The following is a description of a gene set: Human Gene Set: HP_ASCITES studied in species Homo sapiens Accumulation of fluid in the peritoneal cavity (between the layers of the peritoneum that lines the abdomen). Ascites, and this is the list of marker genes: TRIM37, FARSB, ASXL1 (NCBI Gene Id 23393), ARHGAP31, DCDC2, IRF5, GNB2, FH, DIS3L2, SEMA4D, NPC2, GNA11, MTO1, WDR35, SCN4A, ATP6AP2, CCBE1, GBE1, TMEM67, DGUOK, DEF6, TAPT1, PRKCSH, SPP1, TSC1, GRIP1, TNPO3, FSHR, KRT18, TNFSF15, TRIP13, BUB1B, CD55, UBR1, IL12A, TSC2, MRPS22, CBL, POU2AF1, LTBP4, DNASE1L3, ENPP1, ABCB4, USP18, RUNX1, F5, NOTCH1, PLVAP, TFAM, KIF20A, MMEL1, HSD17B4, EPHB4, LCK, WT1, MDFIC, IRAK1, BUB3, CD27, FLI1, SLC17A5, DZIP1L, RHD, GALT, ALG8, MPV17, CALR, STAT4, FAM111A, LBR, ERCC4, AGGF1, MEFV, EWSR1, JAK2, ABCB11, EOGT, FAT4, EIF5A, POLG, TET2, PTH1R, NEU1, MST1, LARS2, HFE, EIF2AK3, LIPA, RNU7-1, ALG9, PKHD1, ABCC6, PIGA, PIK3CA (NCBI Gene Id 5290), PRKAR1A, HLA-DRB1, MYBPC3, FOCAD, ADAMTS3, NPC1, ATP7B, IL12RB1, IFT56, BCL6, ARL6IP6, CYBB (cytochrome b-245 beta chain), SAT1, OSTM1, PRKAG2, RFX6, SPIB, SP110, RBPJ, GPR35, THSD1, GBA1, CEP57, ACTN4, DOCK6, BUB1, ASAH1, TCF4, PRG4, GIMAP5, ATP8B1, NR1H4, SCARB2, GUSB, BMP2, BCL2, SRSF2, FAH, PIEZO1, DLL4, RHBDF2, SOX18, SMPD1